The following is a description of a gene set: The chemical reactions and pathways resulting in the formation of gamma-aminobutyric acid (GABA, 4-aminobutyrate), an amino acid which acts as a neurotransmitter in some organisms. studied in species Homo sapiens Human Gene Set: GOBP_GAMMA_AMINOBUTYRIC_ACID_BIOSYNTHETIC_PROCESS, and this is the list of marker genes: GAD1, ABAT, SLC1A3, GAD2, SLC38A1, ALDH1A1